The following is a description of a gene set: studied in species Homo sapiens Human Gene Set: MIR20A_5P from publication Chen Y, Wang X (PMID 31504780) Genes predicted to be targets of miRBase v22 microRNA hsa-miR-20a-5p in miRDB v6.0 with MirTarget v4 prediction scores > 80 (high confidence targets)., and this is the list of marker genes: ANKH, ST3GAL1, KIF23, WDFY2, ARHGAP26, NAGK, MFN2, PTPRD, TSPAN9, CALD1, ZNF827 (zinc finger protein 827), NPAS2, DUSP8, SERTAD2, MAP3K8 (NCBI Gene Id 8040), TXNIP (NCBI Gene Id 10628), MEX3D, YOD1, PFKFB3, FOXK2, STRIP2, SAMD12, EPHA7, PCDHA12, TRIM3, EPHA4, ATP12A, FAM117B, FRMD6, MFAP3L, WDR37, KANSL1L, KCNJ10, CXCL6, TBC1D17, ADAM9, FSD1L, PSG3, KLHL15, UBE3C, SLMAP, CAPRIN2, EIF5A2, RBBP7, XRN1 (NCBI Gene Id 54464), ZFP91, CREB5, IRF9, BNIP2, NRIP3, CDC37L1, PTGR3, NPLOC4, ANKRD33B, USP46, USP24, AHNAK, RASA2, LRCH1, NHLRC3, ATG16L1, ANKRD29, C14orf28, AMER2, CNOT6L, SAMD8, GNS, TMEM25, ZNF25, PCDHA5 (NCBI Gene Id 56143), TOPORS, BCL11B, KLHL28, AGTPBP1, NFIC, MINK1, P2RX4 (NCBI Gene Id 5025), SORL1, CMPK1, OTUD4, RRAGD, RAB22A, FAM219B, C3orf70, PTPDC1, USP3, UNC80, SOWAHC, VCPKMT, ITGB8, SLC22A23, ABCA1, ENTREP2, PCDHA7, ATG14, NEDD4L, WFS1, ZBTB20, PCDHA10, TET3, SFMBT1, MYLIP, MTMR3, PRR14L, NPAT, ARHGEF3, FAM199X, URI1, ACSL4, MAP3K14 (mitogen-activated protein kinase kinase kinase 14), FZD3, WNK3, RUNX3, APCDD1 (NCBI Gene Id 85500), SLAIN2, PDLIM5, PPP1R3B, TRPV6, IQSEC2, UNK, NBEA, NR2C1, PTPN4, RUFY2, ZFYVE26, SMOC2, BRMS1L, PCDHA11, STK38, RPS6KA4, TMX3, ZNF704, BTBD10, JAK1, ANKRD52, ZBTB9, CFL2 (cofilin 2), CCSAP, SCN2A, CLOCK, TMEM168, PCDH15, MOSMO, CAMTA1, USP28, SPTY2D1, RB1CC1, NABP1, RGMA, GNPDA2, SSH1, FBXL5, FAM13A, ARHGEF11, ORMDL3, THRA, RASGRF2, ZNF202, CPEB3, RAPGEFL1, NAA30, SERF1A, DNAL1, FEM1C, PHC3, ZBTB41, ROCK2, TANC1, FAM210A, CD69, CEP97, SNTB2, DDIAS, PLCB1, AKAP13, JPT1, NACC2, TNKS1BP1, HLF, CCDC71L, KIAA0513, KMT2A, KCNB1, RORC, FAT4, GPR6, TET1, UNKL, AAK1, CDC23, SMAD5, PRCP, DNAJC16, KPNA3 (NCBI Gene Id 3839), PCDHA13 (NCBI Gene Id 56136), HTR2A, ABCD2, NTNG1, PLEKHA3, UBXN2A, CYBRD1, RAB11FIP1, PTPN3, MKNK2, E2F1, HBP1, DCBLD2, HS3ST5, ATG2B, SCN1A, ANKFY1, SLC17A7 (solute carrier family 17 member 7), LMO3, MASTL, ABI1, SIKE1, NIPA1, FASTK, REST, TAFA1, MFSD8, LHX6, SUCO (NCBI Gene Id 51430), AGFG2, BCL2L11 (BCL2 like 11), ARHGAP12 (NCBI Gene Id 94134), ATL3, ZNF597, E2F5, SLC24A2, RASD1, TIAM1, PDGFRA, TNFRSF21, DDX5, MAP3K9, MSR1, MAPK4, OLFM3, RGMB, FLT1, EEIG1, GOSR1, RAB30, MMP2, KIF26B, CHRM2, LIMK1, PFKP, HIF1A, ENPP5, RNH1, OSR1, SMAD4, RNF217, DPYSL5, ZXDA, TAOK1, NAPEPLD (N-acyl phosphatidylethanolamine phospholipase D), SLC49A4, BTBD7, NIN, SOS1, ARAP2, VASP, MAP10, PAK5, USP6, ZBTB7A, RORA, PCDHA1, TAOK3, OSM, ABL2, NCKAP5, LRRC55, TMEM127, S1PR1, SRCIN1, BRWD1, SAR1B, POLR3G, FCHO2, TSG101, KIF3B, PLS1, FYCO1, ULK1, TBC1D9, CLIP4, GPR63, APP, RAB11FIP5, PKD1, NR2C2, MMP24, SSX2IP, ZBTB18, PAPOLB, GRAMD1A, REPS2, PANX2, TMEM265, ZSCAN20, DDHD1 (NCBI Gene Id 80821), ETV1, SOCS6, TUSC2 (NCBI Gene Id 11334), BEST3, L3MBTL3, LYST, PDCD1LG2, SLC16A9, NFIB, DRD1, ELK3, SEMA4B, EMSY, CREB1, TP73, ARHGAP1, NCOA3, MYT1L, PAG1, TBC1D20, LCOR, ATAD2, C2CD2, SERF1B, OXR1, SERP1, CSRNP3, PGM2L1, RRAS2, GPR137C, LRP8, SUSD6, EIF4A2, RETREG3, ZNF512B, ANKIB1, MCHR2, ENTPD4, KMT5B, OCRL, FNBP1L, ITPRIPL2, PARD6B (NCBI Gene Id 84612), NPAS3, LRPAP1, KAT2B, BTG3, TMEM64, PPP3R1, RAP2C, PTHLH, PXYLP1, ZDHHC9, SPOPL, KLHL2, ZNF236 (zinc finger protein 236), ZBTB21, CENPQ (centromere protein Q), MKRN1, SYTL4, KLF9, TBC1D8B, SH3BP5, IL6ST, ST6GALNAC6, DPYSL2, ANKRD13C, OSTM1, FAM13C, WWP2, KMT2B (lysine methyltransferase 2B), NIBAN1, KPNA2, AGFG1, B3GALT2, SESN3, HSPA8, ZNF280B, SPRED1, NKIRAS1, LIMA1, HPS5, FNDC3B, C2orf69, LAPTM4A, PLXNA1, RNF6, PCDHA8, DENND5B, MTF1, MCF2L, HYCC2, NANOS1 (NCBI Gene Id 340719), FGD5, EGR2, RNASEH2B, STK11, ANKRD50, TGFBR2, ZNF652, ZHX2, ABHD5, RAB8B (RAB8B, member RAS oncogene family), PKD2, TMEM100, KLF11, GPR137B, VSX1 (visual system homeobox 1), ERAP1, AP2B1, ZNF264, BAMBI, OSBPL5, DOCK4, ABCG4, PDE3B, UBE2D1, MAP7, TMEM138, FRS2, CNRIP1, SGMS1, PPP1R15B, FGL2, ANKRD17, MAGI3, CAPN15, CD274 (CD274 molecule), GOLGA1, NEUROG2, ARHGEF28, ATXN1L, PLXDC2, SLC45A4, ARMC8, PCDHAC2, FAT2, BICC1, PTGDR, CHD5, NEUROG1, EPS15L1, SLC4A8, SCN2B, PRDM6, STK17B, PRR15, SLITRK2, NTN4, ELK4, MAP3K2, ARHGEF10, SH3PXD2A, ZC3H12C, PBX3, SOX4, ZBTB47, PEX5L, ZFAND4, BTN3A1, EGLN3, RACGAP1, CHP2, RETREG2, CRYBG3, FBXO48, FBXO31, MAPRE3, NUP35, CMKLR1, GPATCH2, LDLRAP1 (NCBI Gene Id 81862), LASP1, CNOT6, BNC2, SLC40A1, TRIP11, RAPH1 (NCBI Gene Id 80729), TNFAIP1, CNOT4, PTPN21, DNAJB9, SLITRK3, DERL2, LYPD6, RAB10, BMPR2, ZBTB8A, SQSTM1, ERC1, TRIP10, CC2D1A (NCBI Gene Id 54862), TAGAP, CNOT7, ARHGEF18, FBXO21, TNKS2, U2SURP, PPP6C, CORO2B, TPRG1L, SEPTIN2, CTSA, ZNF2, DLGAP1, BAHD1 (NCBI Gene Id 22893), AGO1, ITGA4, GUCY1A1, NFAT5, SCAMP2, RAB12, SNX16, UBE2Q2, MYNN, STXBP5, MED12L, AFG1L, RCCD1, ZFYVE9, BHLHE41, NDEL1, ANO6, HAS2, PLAG1, CCNG2, MCL1, IL1RAP, SNX8, DUSP2, REV3L, FOXJ3, BBX, PURB, TRAPPC14, CMTR2, RSRP1, PCDHA3, LRIG1, ZBTB33, TRDN, SLC30A7, CRK, PRRG1 (NCBI Gene Id 5638), PITPNA, PHIP, CERCAM, SEMA7A, RAB5B (RAB5B, member RAS oncogene family), ISM2, PCDHA6, RBM12B, GAB1, GLIS3, SRGAP1, RBL1, SLC4A4, GNB5, RLIM, CDKN1A, CEP170, UEVLD, GABPB1, GXYLT1, PAPOLA, TRIM37, ZNF800, CBLN4, RASL11B, FAS, BICD2, CROT, ST6GALNAC3, PSD, TRIM36, DYNC1LI2, LZIC, RPS6KA6, ZFPM2, ZNFX1, KIAA1191, STAT3, SLC33A1, RGL1, LAMA3, MAPK1, IKZF4, FBXL3, TMEM167A, IRF1, PCDHAC1, ABHD2, EFCAB14, SLC46A3, FGD4, KATNAL1, RNF128 (ring finger protein 128), HECTD2, ARID4B, CCND1, ZNF367, CTSK, PAFAH1B1, EREG, PXK, RHOC, VASH2, DAB2, HAUS8, UXS1, PCDHA4, MIDN, AKAP11, REEP3, SSH2, USP31, ARID4A, FJX1, USP32, ZDHHC1, HEG1, AKTIP, WDFY3, SCAMP5, EZH1, SRPK2, TGM2, RPS6KA5, MAP3K20, SACS, LPGAT1, TFAM, PGBD5, DENND10, SLC16A6, ADARB1, ZBTB4, LDLR, EPHA5, PCDHA2, RRM2, DCUN1D1, VLDLR, KCNK10, CEP120, PPP1R21, PHLPP2, DNAJC27, SALL3, C6orf120 (chromosome 6 open reading frame 120), PRR16, KLF12, MARCHF8, PLAGL2, SMOC1, PIK3R1, VANGL1, GABBR2, IGSF10, ZNF148, TENM1, RBL2, SALL1, TM2D2, F3, CRY2